Given this list of marker genes COL11A2, DMD, PRPF38B, NBEA, CTDSP1, KPNB1, SLC6A10P, CPA2, SLC38A3, TFAP2D, EIF5A, ZNF768, NR6A1, PRLR, BMAL1, TGFB3, ATP2A2, PCBP4, NT5DC2, ZMYM2, HELZ2, ZBTB10, CACNG2, BCL9 (NCBI Gene Id 607), DCHS2, KCNB1, ARHGEF5, KCNC1, PAX6, PAGR1 (PAXIP1 associated glutamate rich protein 1), RSF1, RBM14, HOXB6, SLC25A28, TLX1, NIPBL, GPR52, SGK1, AAMDC, PRKAG2, GPBP1L1, IL11, STIM1, DIAPH1 (diaphanous related formin 1), DDAH2, LRRC17, BTF3P11, ZNF385A, ACVR2A, VEGFA, ROCK1, TMEM38A, ERBIN, AZI2, GGT7, POM121L1P, COL12A1, RORC, ELAVL3, YBX2, RBM24, POU2F1, UBR5, SIGLEC7, SEPTIN4, ZFX, SLC50A1 (NCBI Gene Id 55974), ARMCX6, HOXA13, GPR173, ST6GALNAC5, PPP4R1, PTPN22, PPP2R5B, CHD2, GRM1, KCNK3, ZNF436-AS1, TSC22D3, PITX2, EPN1, GPC3, CYP24A1, NDUFS2, LMO3, FBRS (NCBI Gene Id 8734), NDUFV1-DT, SPATA20, LAMP5, SSBP3, SIGMAR1, HOXC13, SREK1, USH1C, MEX3B, TRIM8, AQP9, MYO1E, PTCH1, PDGFB, ERRFI1, FKBP11, TMEM88, PCDH7, ADAMTS4, XPO1, ZNF436, CDC27, KANSL1, PKP3, B3GALT2, NAT8L, SYNC, RBBP6, HYAL2, ASXL1, YWHAG, TMPO, MAGEH1, BAHD1, NREP, TTC3 (NCBI Gene Id 7267), UQCRFS1, TRIM41, ASXL2, FGR, IKZF2, CTNNBIP1, ARID4A, CCDC177, SLC7A3, ST8SIA2, AQP1, SLC35E1, NKX2-1 (NK2 homeobox 1), SALL1 (spalt like transcription factor 1), HOXB7, SLC26A3, PATZ1, SLC26A9, HPCA, TFAP4, MRI1, FRMD5, FLI1, SSBP2, LIN28A, HSPB7, SARNP, here is a description of the gene set: species: Homo sapiens Genes having at least one occurrence of the motif RRTGNMCYTNNTGAMCCNYNT in the regions spanning 4 kb centered on their transcription starting sites. This matches the VDR transcription factor binding site V$DR3_Q4 (v7.4 TRANSFAC). Human Gene Set: DR3_Q4